Given this list of marker genes SRP9, ELOB, ELOC, EEF1B2, EEF1A1, RPLP2, RPLP1, EEF1A2, TUFM, EEF2, EEF1G (eukaryotic translation elongation factor 1 gamma), EFTUD2, RPLP0, EEF1D, EIF2S3, here is a description of the gene set: studied in species Homo sapiens Ttranslation elongation. Human Gene Set: MODULE_150